The following is a description of a gene set: studied in species Homo sapiens Human Gene Set: HP_CUTIS_MARMORATA Cutis marmorata A reticular discoloration of the skin with cyanotic (reddish-blue appearing) areas surrounding pale central areas due to dilation of capillary blood vessels and stagnation of blood within the vessels. Cutis marmorata generally occurs on the legs, arms and trunk and is often more severe in cold weather., and this is the list of marker genes: RAD21, ARHGAP31 (NCBI Gene Id 57514), AGXT, SMC3, RNASEH2C, ACTA2, GNA11, CBS, FTO, ARL6IP6, THSD4, TGFBR1, TGFB3, NOTCH1, PTDSS1, SMAD4, NFIX, TREX1, MYD88, LARP7, HDAC8, SMAD2, HEATR3, POLA1, NSUN2, DOCK6, PRKG1, FOXE3, MFAP5, RNF113A, DDX11, NIPBL, SOX18, RNU7-1, UBAP2L, ADAR, LIG4, AKT3, LSM11, TAF6, GUCY1A1 (NCBI Gene Id 2982), RPS6KA3, HEY2, ADA2, RNASEH2A, DLL4, TGFBR2, IFIH1 (interferon induced with helicase C domain 1), ELN, CAV1, NFIA, SAMHD1, MYLK, BRD4, FBN1, RBPJ, STAG1, ABL1, EOGT, SMAD3, RNASEH2B, LOX, PIK3CA, DHCR7, MYH11, FOSL2, PTEN, MAT2A, ABCC9, TGFB2, ARID1B, H4C3, STING1, SMC1A